Given this list of marker genes Hmgb1, C1qtnf2, Irs2, Phkb, Phka1, Gck, Insr, Irs1, Phkg2, Ppp1r3g, Ins2, Igf2, Ppp1r3e, Adcy10, Ins1, Pth (parathyroid hormone), Adra1b, Igf1, Akt1, Ppp1ca, Dyrk2, Sorbs1, Ppp1r3b, Phkg1, Epm2aip1, Akt2, Esrrb, here is a description of the gene set: Any process that activates or increases the frequency, rate or extent of the chemical reactions and pathways involving glycogen. Mouse Gene Set: GOBP_POSITIVE_REGULATION_OF_GLYCOGEN_METABOLIC_PROCESS species: Mus musculus